Given this list of marker genes CDC23, ANAPC16, UBE2E1, BUB1B, ANAPC11, ANAPC5, ANAPC4, UBE2D1, ANAPC1, UBE2C, MAD2L1, CDC27, ANAPC2, BUB3, ANAPC15, CDC20, UBE2S, CDC16, ANAPC7, CDC26, ANAPC10, here is a description of the gene set: studied in species Homo sapiens In the direct inhibition model, the cytosolic Mitotic Checkpoint Complex, consisting of hBUBR1, hBUB3, Cdc20 and Mad2, directly inhibits APC/C by binding to it. Reactome Pathway: Inactivation of APC/C via direct inhibition of the APC/C complex part of: Inhibition of the proteolytic activity of APC/C required for the onset of anaphase by mitotic spindle checkpoint components